The following is a description of a gene set: Catalysis of the reaction: retinal + NAD+ + H2O = retinoate + NADH. Acts on both 11-trans and 13-cis forms of retinal. species: Homo sapiens Human Gene Set: GOMF_RETINAL_DEHYDROGENASE_ACTIVITY, and this is the list of marker genes: ALDH8A1, ALDH1A2, AKR1B1 (NCBI Gene Id 231), AKR1C4, AKR1C3 (aldo-keto reductase family 1 member C3), ALDH1A3, ALDH1A1 (NCBI Gene Id 96075), AKR1B10